The following is a description of a gene set: Human Gene Set: GOBP_RESPONSE_TO_RETINOIC_ACID studied in species Homo sapiens Any process that results in a change in state or activity of a cell or an organism (in terms of movement, secretion, enzyme production, gene expression, etc.) as a result of a retinoic acid stimulus., and this is the list of marker genes: LEP (leptin), RARA (retinoic acid receptor alpha), RORB, YES1, IGFBP2, PTCH1, PHC1, SLC10A3, WNT3, EPHA3, DRD2, TIE1, GATA6, DUSP1, WNT9B, NTRK3, MYB, TWF2, TBX1, GDAP1, CDKN2D, GDAP2, CD38, WNT5B, SNRNP70, MEST, BRINP3, OVCA2, ATM (NCBI Gene Id 8068), OXT, WNT6, NDUFA13, RARG, SP100, SERPINF1, SLC6A4, COL1A1, RBP4, HAND2, TFRC, WNT9A, IGF2R, MMP2, YAP1, FZD7 (NCBI Gene Id 8324), HTRA2, WNT8A, OSR1, TRIM16, HOXA2, RXRB, TESC, PAX2, FGFR2, RET, PTK2B, TNF, PTK6, LYN, IGFBP7, WNT11, DKK1, MEIOSIN, RXRA, FZD4, SNW1, TEAD2, NCOA1, ABCA1, SOX9, ALDH1A2, BRINP2 (NCBI Gene Id 57795), WNT2, BMP6, CYP26B1, MICB, KLF4, WNT8B, TRIML2 (NCBI Gene Id 205860), AQP1, FZD10, CREB1, HSD17B2, CTSH, HDAC2, WNT10B, TBX2, DNAAF2, STRA8, ANKK1, WNT3A, ACER2, TNC, TMEM161A, WNT7B, CYP26A1, ASXL1, LRAT, AQP3, PTK7, ASCL1, BRINP1, SREBF1, WNT5A, ABL2, GSK3B, ZNF35, LTK